The following is a description of a gene set: Genes having at least one occurrence of the motif NNWWWWNGMCACGTCATYNYWNNN in the regions spanning 4 kb centered on their transcription starting sites. This matches the transcription factor binding site V$HTF_01 (v7.4 TRANSFAC). species: Homo sapiens Human Gene Set: HTF_01, and this is the list of marker genes: CPNE1 (NCBI Gene Id 8904), GBF1, SRP54, NKX2-2, NPAS2, JADE1, STT3A, ZNF280C, HMGB1, COG3, IL1RAPL1, FKBP14, UBQLN1, MN1, GRIA3, UFC1, CWC25, SYT11, TYRO3, ARMCX2, PIP5K1A, PAK1IP1, HM13, ZBTB47, BCL11B, MORF4L2, EML1, SGK1, HOXA9, RBM26, NUMBL, NLGN2, SIK2, SND1 (staphylococcal nuclease and tudor domain containing 1), ELF1, NHSL2, BUB3, USO1, ASXL2, OLIG3, RFX4, DNAJB4 (NCBI Gene Id 11080), SEC61A1 (SEC61 translocon subunit alpha 1), DNM3, DHDDS, ZFHX3, COL1A2, PRRX1, JADE2, CCND1, ZIC4, POLG, HMBOX1, RGS1, QRICH1, ATRNL1, INTS9, NMNAT2, CREB3L1, KLF14, TSSK2, SRSF2, ARL5B, SOX14, STAT3, TSPAN13 (NCBI Gene Id 27075), HOXC4, AMER2, SUCO, TSHZ3, PCYT2, HID1